The following is a description of a gene set: Cytokines mediate cell-cell communication in the immune system and represent important therapeutic targets. A myriad of studies have highlighted their central role in immune function, yet we lack a global view of the cellular responses of each immune cell type to each cytokine. To address this gap, the authors created the Immune Dictionary, a compendium of single-cell transcriptomic profiles of more than 17 immune cell types in response to each of 86 cytokines (>1,400 cytokine-cell type combinations) in mouse lymph nodes in vivo. A cytokine-centric view of the dictionary revealed that most cytokines induce highly cell-type-specific responses. For example, the inflammatory cytokine interleukin-1β induces distinct gene programmes in almost every cell type. A cell-type-centric view of the dictionary identified more than 66 cytokine-driven cellular polarization states across immune cell types, including previously uncharacterized states such as an interleukin-18-induced polyfunctional natural killer cell state. from publication Cui A, Huang T, Li S, Ma A, Pérez JL, Sander C, Keskin DB, Wu CJ, Fraenkel E, Hacohen N (PMID 38057668) Mouse Gene Set: CUI_T_CELL_CD4_IL17C_RESPONSE_DN Genes negatively differentially expressed in cell type: CD4+ T cell upon treatment with cytokine: IL-17C in mouse lymph nodes in vivo. studied in species Mus musculus, and this is the list of marker genes: Hspa1a, Tsc22d3, Hspa1b (NCBI Gene Id 15511), Hspa8, Btg2, Uba52, Jun, Klf6, Dnajb1, Junb, Fos, Jund, Ppp1r15a